The following is a description of a gene set: Human Gene Set: GOBP_REGULATION_OF_CYTOKINETIC_PROCESS studied in species Homo sapiens Any process that modulates the frequency, rate or extent of a cytokinetic process., and this is the list of marker genes: KIF20B, ARF6, ECT2, RAB11A (RAB11A, member RAS oncogene family), NUP62, RAB11FIP3, EXOC7